Given this list of marker genes Slc26a1, Slc13a1, Slc26a2, Slc13a4, Slc26a6, Slc26a5, Slc26a8, Slc26a3, Slc26a4, Ucp2, Slc26a11, here is a description of the gene set: Mouse Gene Set: GOMF_SECONDARY_ACTIVE_SULFATE_TRANSMEMBRANE_TRANSPORTER_ACTIVITY studied in species Mus musculus Enables the secondary active transfer of sulfate from one side of a membrane to the other. Secondary active transport is the transfer of a solute across a membrane, up its concentration gradient. The transporter binds the solute and undergoes a series of conformational changes. Transport works equally well in either direction and is driven by a chemiosmotic source of energy. Secondary active transporters include symporters and antiporters.